Given this list of marker genes SPCS3, CREB3L2, ERLEC1, BLOC1S5-TXNDC5, RAB30, PTK2B, CD79A, PRDX4, DERL3, HSP90B1, SDC1, ISG20, FKBP11, SPAG4, SPCS2 (NCBI Gene Id 9789), SEC11C, SSR4, JCHAIN, NUCB2, POU2AF1, MEI1, XBP1, HERPUD1, MZB1, MYDGF, SLAMF7, ITM2C, FKBP2, TMEM258, SEL1L3, CD27, TENT5C, H1-10, LY9, FCRL5, here is a description of the gene set: studied in species Homo sapiens Human Gene Set: AIZARANI_LIVER_C8_RESIDENT_B_CELLS_1 from publication Aizarani N, Saviano A, Sagar, Mailly L, Durand S, Herman JS, Pessaux P, Baumert TF, Grün D (PMID 31292543)